Given this list of marker genes ZNF205, JAM3, TMEM14A, CAMK2A, TMIGD1, MPV17L, GSK3B (glycogen synthase kinase 3 beta), IER3, GSK3A, BCL2, NAIF1 (NCBI Gene Id 203245), BNIP3L, RHOT2, PPIF, NOL3, STAT3 (NCBI Gene Id 6774), MIR142, HSPA1A, PDCD6IP, BID, TMEM102, CHCHD10, MUL1, SLC9A1, BCL2L1, LAPTM4B, MYLK3, MIR146A, MIR29C, PMAIP1, ALKBH7, THEM4, ATP5IF1, CLDN3, RHOT1, GCLC, ARHGAP11B, FZD9, RASIP1, LAPTM5, HIP1R, PPM1K, TP53, DEFA5 (NCBI Gene Id 1670), SLC25A6, BLOC1S2 (biogenesis of lysosomal organelles complex 1 subunit 2), EYA2, BAK1, ACAA2, BOK, MIR29B1, LRRK2, HEG1, VDAC2, SLC25A4 (NCBI Gene Id 7872), APOLD1, SIVA1, ATF2, SLC25A5, MIR29A, BAX, F11R, RTL10, BAD, MTCH2, BCL2L11, MIR17, SLC35F6, SLC25A31, MTOR, BNIP3, TJP2, HK2, STPG1, SPG7, here is a description of the gene set: Human Gene Set: GOBP_REGULATION_OF_MEMBRANE_PERMEABILITY Any process that modulates the frequency, rate or extent of the passage or uptake of molecules by a membrane. species: Homo sapiens